Given this list of marker genes SLC1A2, SLC1A7, SLC7A11, SLC25A22, SLC1A1, SLC1A6, SLC1A3, SLC17A7, SLC17A8 (NCBI Gene Id 64944), SLC38A2, SLC17A6, SLC25A18, SLC1A4, UCP2 (NCBI Gene Id 7351), SLC25A13, SLC25A12, SLC38A6, SLC1A5, here is a description of the gene set: Enables the transfer of acidic amino acids from one side of a membrane to the other. Acidic amino acids have side chains with a negative charge at pH 7.3. Human Gene Set: GOMF_ACIDIC_AMINO_ACID_TRANSMEMBRANE_TRANSPORTER_ACTIVITY studied in species Homo sapiens